Given this list of marker genes CDC42BPB, MGAT2, CNTNAP2, FGF5, EP300, MAB21L2, MBD5, RNF2, DVL1, TBX4, WNT5A, SHOC2, HDAC8, GJA5, TMCO1, PUF60, PGM2L1, AP3B2, CCDC47, SMARCA2, MAF, CAMTA1 (calmodulin binding transcription activator 1), SLC25A24, RUSC2 (RUN and SH3 domain containing 2), ARID1B, CHD1, C1GALT1C1, EXOC8, GJA8, BRD4, SLC35C1, EGFR, SOX11, NRCAM, SLC4A10, CAMKMT, PPM1B, NXN, SMARCC2, SMARCA4, RHOBTB2, NOTCH2, NIPBL, KCNH1, ROR2, RAC3, SMC1A, ASCC3, KCNK9, VARS1, CLP1, CHMP1A, DPYD, CREBBP, H4C5, BICRA, SLC3A1, NAA10, FRMD4A, SPEN, ATP6V1B2, COX5A, BRCA1, FBN1, HID1, PACS1, HECTD4, ARID1A, FZD2, LTBP3, RPS23, CSF1R, TIMM50, GNB2, DOCK7, DEPDC5, DDB1, ORC1, KCNK4, ARHGEF2, BMP1, VPS51, SHANK3, OTUD6B, KMT2A, DENND5A, SMC3, PREPL, ZNF699, ASXL2, CNOT2, DVL3, MADD, KCNN3, FBXO11, SPOP, CTCF, SEC31A, VPS33A, HPDL, TBCK, VPS13B, ABCC9, SLC6A9, PNPLA6, KCNJ8 (NCBI Gene Id 3764), MAN1B1, LTBP1, FBXL4, RAD21, MAB21L1, SATB2, ASXL3 (NCBI Gene Id 80816), SLC30A9, KMT2D, RNU4-2, TAF1, KDM6A, ACTB, STAG1, AFF4, SMARCB1, SMAD4, TENT5A, SRCAP, UFC1, MED27, HSPG2, MOGS, ESAM, SMARCE1, TAF6, PRR12, here is a description of the gene set: Human Gene Set: HP_LONG_EYELASHES Mid upper eyelash length >10 mm or increased length of the eyelashes (subjective). Long eyelashes species: Homo sapiens